The following is a description of a gene set: from publication Heller G, Schmidt WM, Ziegler B, Holzer S, Müllauer L, Bilban M, Zielinski CC, Drach J, Zöchbauer-Müller S (PMID 18172295) To identify epigenetically silenced cancer-related genes and to determine molecular effects of 5-aza-2'-deoxycytidine (Aza-dC) and/or trichostatin A (TSA) in multiple myeloma (MM), we analyzed global changes in gene expression profiles of three MM cell lines by microarray analysis. We identified up-regulation of several genes whose epigenetic silencing in MM is well known. However, much more importantly, we identified a large number of epigenetically inactivated cancer-related genes that are involved in various physiologic processes and whose epigenetic regulation in MM was unknown thus far. In addition, drug treatment of MM cell lines resulted in down-regulation of several MM proliferation-associated factors (i.e., MAF, CCND1/2, MYC, FGFR3, MMSET). Ten Aza-dC and/or TSA up-regulated genes (CPEB1, CD9, GJA1, BCL7c, GADD45G, AKAP12, TFPI2, CCNA1, SPARC, and BNIP3) were selected for methylation analysis in six MM cell lines, 24 samples from patients with monoclonal gammopathy of undetermined significance (MGUS), and 111 samples from patients with MM. Methylation frequencies of these genes ranged between 0% and 17% in MGUS samples and between 5% and 50% in MM samples. Interestingly, methylation of SPARC and BNIP3 was statistically significantly associated with a poor overall survival of MM patients (P = 0.003 and P = 0.017, respectively). Moreover, SPARC methylation was associated with loss of SPARC protein expression by immunostaining in a subset of MM patients. In conclusion, we identified new targets for aberrant methylation in monoclonal gammopathies, and our results suggest that DNA methyltransferase and histone deacetylase inhibition might play an important role in the future treatment of patients with MM. species: Homo sapiens Human Gene Set: HELLER_HDAC_TARGETS_SILENCED_BY_METHYLATION_UP Genes up-regulated in multiple myeloma (MM) cell lines treated with both decitabine TSA., and this is the list of marker genes: BEX4, ZBTB43, CGREF1 (cell growth regulator with EF-hand domain 1), DMRT1, MICALL2, NPTX2, CRIP2, SYN1, CDKN1C, FZD5, NFYA, NAT1, PRKCB, MET, MAGEA3, DDAH2, RASGRP2, PDGFRL, KCNN2, SPIB, CDK18 (NCBI Gene Id 5129), OAT, H3C2, ING1, ALDH2, C3, SCP2, SELENOP, H2AC8, EFHC1, HLA-DPA1, ABTB2, KIF5C, ABCB1, VCX, H2AC25, TIMP1, SPINK2, CDKL3, ITGA6, TAC1, FLNB, KIZ, CEP55, NUP93, EGR4, TUBB2A, MAPT, SWAP70, ARMCX2, SPAG6, MAGEA9, MYOF, TFRC, KIAA0513, DOP1A, H1-6 (H1.6 linker histone, cluster member), DHRS2, TLE4, RCN3, DNM3, ACSL3, FER, PGF, APLP1, MICAL2, PLXNB3, SQSTM1, MT1H, ATF7IP2, KHK, ACADSB, SPTLC2, H2BC8, ITGBL1, STAT3, TMEM47, HLA-DPB1, SYT11, NAP1L3, SERPINB5, DLX2, SEPTIN4, FTL, KLHL24, UNC119 (unc-119 lipid binding chaperone), FOS, HABP4, TROAP, NRXN1, IFI6, H3C12, FBP2, PLEC, GPM6A, KRT18 (NCBI Gene Id 3875), NUDT11, ORC5 (NCBI Gene Id 5001), NAB2, SDC4, HSPA1A, SH3GL3, SLC25A44, LAMP3, H4C14, AKAP13, GAL, CSRP2 (NCBI Gene Id 7882), KLF2, CCK, MAGEC1, SNAI1, ITGA7, MT1E, PLPPR2, CDC14B, RHOB, IER3, ID1, MAGEB2, TCEAL9, TMEM127, SSX3, MAFB, PRKAR2B, PCLO, PIK3CD, CLIP2, NTS, EHHADH, NRGN, CACNA1G, SPAG9, LGSN (NCBI Gene Id 51557), SERPINF1, H4C8, CYP1B1, KATNB1, HLA-DRB1, MAPRE3, ERO1B, AHR, ALDH1A3, HPSE, LPCAT3, BAIAP2, PHLDA2, NEFL, FBN1, FN1, BIN1, DSE, ARL6IP1, FGFR4, S100A4, ZSWIM8, DDX4, TKTL1, SLC16A4, ASMTL, MGST3, RBFOX2 (NCBI Gene Id 23543), SH3BGR, TSPAN13, TFAP2C, MAPK8IP1, DZIP1, NEU1, IFIT1, DPEP3 (NCBI Gene Id 64180), RNF128, IZUMO4, TAOK3, NABP1, IL15, BLTP1, COL6A2, GLDC, CRISPLD2, TTLL1, BMP2K (NCBI Gene Id 55589), CNTNAP2, FTCD, CYRIA, BIK, HBA2, ATP6V0D1, FHL1, H4C2, KCTD12, MSH5, DNAH3, BIRC3, GMPR, SLC4A8, BEX3, GLUL, SLC16A3, SAT1, PPP2R3B, ZER1, RPS6KA2 (NCBI Gene Id 6196), FSCN1, CTSV, APLP2, RADX, SGK3, TFPI2, FGD6, HSD17B11, C1S, UBE2S, MFSD12, TPM1, TUFT1, SNAP23, ID2, SORT1, ARG2, STAT1, DBN1, SSX1, RRAS, ANKRD6, TRIP6, SOX4, H2BC4, TLN2 (talin 2), JAG1, PAEP, TMEM143, CEL, HSPA2, MYBL1, RRBP1, H2AC17, PPL, H2BC21 (H2B clustered histone 21), ENAH (NCBI Gene Id 55740), H4C12, RHCE, AKR1C3, H3C8, JPT1, BCL6, CEP15, ZNF10, CCNF, BAIAP3, UBD, H2AC6, LIFR (NCBI Gene Id 3977), APOE, H2AB3, TST, IL13RA1, FLNA, CTH, JUP, RRAD, DDX43, AGRN, ZNF556, POLR2L, GAGE2A, HBA1, PTGER4, ATP1B1, H2BC3 (NCBI Gene Id 3018), ATP6AP2, MEF2C, ENPP2, EGR1, NR4A2, IGFBP3, TXNRD3, DUSP2, MIR22HG, FKBP1B, EGR2, HK1, ALDH4A1, AREG, DZANK1, CGB3, HLA-DRB4, CSPG5, CFH, COL14A1 (collagen type XIV alpha 1 chain), ARMC9, SLC12A8, TDRD12, SLC25A31, GAGE1, JAG2, CDH19, CD24 (CD24 molecule), NCAN, FDXR, TSPAN12, H3C10, H2AC11, PFN2, CEP131, TADA3, ODC1, ABHD5, LHX2, FGFR3, PMEL, LONP2, CXCL11, HES1, TUBA1A, CALM1, TENM1, POR, PYY, GATA3, ENSG00000310059, MARCKSL1, CCNA1 (cyclin A1), FOXG1, CDKN1A, TUBG1, AP5Z1, GSN, AKAP12, SLC9A1, GRN, WDR7, ZNF557, SERPINI1, H3-4, H1-0, PRSS2, AASS, NR1H4, EIF4EBP2, SERPINE2, DAZL (NCBI Gene Id 1618), ATG2A, CAMTA1, IFI27, ALDOC, TUBB6, HPGD, RUNDC3B (NCBI Gene Id 154661), SYT1 (NCBI Gene Id 6857), ATP13A2, CYP1A1, TFPI, NEDD9, ZCCHC14, OGDHL, SSX2, TUBB3, NR4A1, PEG10, EFNB2, H2AC13, ABAT, GNS, L1CAM, TMOD1, PIGV (NCBI Gene Id 55650), TOX3, PFKFB3, PRPH, ALPG, AAMDC, SFXN3, PGBD5, TUBB4A, MYCN, ATG12, MSX1, H2BC10, RAB13, MAGEA6, DZIP3, ITSN1, SMARCD3, RAI2, BRCA2, NCAM1, ALPP, TFEC, WASF1, TXNIP, H2AC18, SNAP25, KDM5B, ADCY9, GPSM2, DYRK3, TULP3, PLS1, H1-2, MT2A, DENND5A, CDH1, PTK2, MLF1, GM2A, RNFT2, BTG1, AHNAK2, RTN2, ACSBG1, CDR2L, KIF4A, SMPD3, HLA-DQA1, ELOA-AS1, DUSP1, EPHA3, DLGAP5, MAGEA4, PLK2 (NCBI Gene Id 10769), H3C4, ZBTB18, TIMP3, RPS20, HSD17B1, GLCE, SLC6A8, MT1X, G6PD, MYO9B, COTL1, TMSB15A, ADARB1, CD9, CSTA, PDLIM5 (PDZ and LIM domain 5), MAGEA11, TOP2A, HOXA1, SLC17A7, PPM1E, EPAS1, PCDH9, ULBP2, CYP26B1, ALCAM, UQCRFS1, FUCA1, PPARD, FGFR1, ATP6V1D, SORBS1, MAP9, CGA, ACOT7, SPP1, NIPAL3, NXN, PSAP, ZMAT3, NUP62CL, TUBB2B